Given this list of marker genes ODC1, OAZ3, AZIN2, OAZ2, AZIN1, OAZ1, here is a description of the gene set: Human Gene Set: GOMF_ORNITHINE_DECARBOXYLASE_ACTIVITY Catalysis of the reaction: L-ornithine + H+ = CO2 + putrescine. studied in species Homo sapiens